The following is a description of a gene set: species: Mus musculus Genes positively differentially expressed in cell type: NK cell upon treatment with cytokine: IFN-β in mouse lymph nodes in vivo. Cytokines mediate cell-cell communication in the immune system and represent important therapeutic targets. A myriad of studies have highlighted their central role in immune function, yet we lack a global view of the cellular responses of each immune cell type to each cytokine. To address this gap, the authors created the Immune Dictionary, a compendium of single-cell transcriptomic profiles of more than 17 immune cell types in response to each of 86 cytokines (>1,400 cytokine-cell type combinations) in mouse lymph nodes in vivo. A cytokine-centric view of the dictionary revealed that most cytokines induce highly cell-type-specific responses. For example, the inflammatory cytokine interleukin-1β induces distinct gene programmes in almost every cell type. A cell-type-centric view of the dictionary identified more than 66 cytokine-driven cellular polarization states across immune cell types, including previously uncharacterized states such as an interleukin-18-induced polyfunctional natural killer cell state. Mouse Gene Set: CUI_NK_CELL_IFNB_RESPONSE_UP from publication Cui A, Huang T, Li S, Ma A, Pérez JL, Sander C, Keskin DB, Wu CJ, Fraenkel E, Hacohen N (PMID 38057668), and this is the list of marker genes: Psmb2, Etnk1, Sp100, Mrto4, Parp14, Crem, Tmem243, Tmsb10, Mrpl30, Tor3a, Hspe1, Ptpn1, Magohb, Helz2, Igtp, Lilrb4b, Cyrib, Parp9, Rsad2, Ifih1, Cytip, Cd86, Gcnt1, Hspa8, Clec2d, Zup1, Socs1, Vps37b, Plac8, Tmbim6, Larp7, Trafd1, Ifrd2, Nedd9, Ptges3, Cish, Cd164, Abracl, Snrpd1, Cct5, Ufd1, Gbp4, Sar1a, Tcp1, Phf11c, Daxx, Nhp2, Ddx60, Evi2a, Zfp593, Trim12c, Apobec1, Pnpla2, Gng2, Tubb4b, Atp6v1g1 (ATPase, H+ transporting, lysosomal V1 subunit G1), Nop56, Adar, Nfkbiz, Ahsa1, Agpat3, Tes, Dtx3l, Ifi204, Map2k1, Ran, Ms4a4c, Tcstv4, Gng12 (guanine nucleotide binding protein (G protein), gamma 12), Gns, Selenok, Parp12, Slfn5, Pdia3, Dnajb11, Sfxn2, Atp5pb, Bag1, Cd69, Nars1, Rtp4, Ifi203, Gbp8, Creld2, Xcl1, Tmem248, Gnpnat1, Pomp, Laptm4a, Aurkaip1, Irf8, Casp1, Pole3, Slamf7, Bst2 (NCBI Gene Id 97478), Stat1, Cct7, St6galnac4, Mat2a, Isg15, Dnaja1, Sh2d1b1, Rnf213, Slfn1, Ebna1bp2, Timm8a1, Nt5c3, Hspd1, Exosc3, Ddx39a, Dkc1, Napsa, Svbp, Arf6, Ms4a6b (membrane-spanning 4-domains, subfamily A, member 6B), Sell, Arpc5, Psmb8, P2ry14, Strap, Ppa1, Psma5, Cntrl, Cysltr2, Smndc1, Ssr1, Gbp2, Bltp3b (NCBI Gene Id 97652), Ccnd2, Fyn, Lgals9, B4galt5, Rel, Aldoa, Nfkbib, Dgkh, Jaml, Ywhae, Myc, Nlrc5, Tbx21, Ifi213, Sp110, Ezr, Calr, Capza2, Usp18, H2-D1, Fhl2, Eif2ak2, Epsti1, Fnbp4, Cd47, Plaat3, Pgd, Zbp1, Ndufb4, Cpne3, Tap2, Ctss, Gbp7, Nab1, Gbp5, Rbm3 (NCBI Gene Id 72067), Txn1, Srsf6, Gnl3, Nop58, H13, Ncl, Ccrl2, Rigi, Mapkapk2, Max, Gadd45g, Tmem184b, Sub1, Cxcl10, Smchd1, Stom, Ptma, Sdc3, Ahr, Ifi214, Eif1, Ly6a, Tspan13, Mx1, Psma2, Lamp2, Nkg7, Ddx21, Klrk1, Nip7, Nampt, Derl2, Riok1, Gzmb, Pa2g4, Dph3, Irf1, Phf11b, Fam111a, Irgm1, Lsm4, Znfx1, Cd53, Apobec3, Myd88, Iigp1, Prps1, Nmi, Actg1, Dennd4a, Gbp9, Oasl1, Plscr1, 9930111J21Rik2, Furin, Bzw1, Rabepk, Psmc4, Tspo, Tnfsf8, Tmed10, Tdrd7, Prkcq, Magoh, Lilrb4a, Dhx58, Parp10, Tapbp, Cmpk2, Rab5c, Ccl3, Snx3, Actr3, Arf1, Cct3, Ostc, Hsp90aa1, Pfdn2, Bbx, Trim34a, Samsn1, Sipa1l1, Gem, Pttg1, Usp25, Gpr65, Tap1, Phf6, Nsd3, Eif5a, Samd9l, Xbp1, Rab8b, Serpina3f, Frmd4b, Casp4, Eif4e, Stk39 (serine/threonine kinase 39), H2-Q7, Ndufs4, Ifi211, Baz1a, Dgat1, Rfk, Eef1e1, Sec61g, Gpr171, Mitd1, Mov10, Spcs2, Emc7, Trim25, Ifitm3, Ccl4, Psmb10, Slfn8, Ubald2, Il12rb1 (interleukin 12 receptor, beta 1), Psma3, Ddx24, Ube2i, Sem1, Cacybp, Stat2, Cox17, Anapc15, Serpinb9 (NCBI Gene Id 20723), Ccr5 (NCBI Gene Id 235693), Slc44a2, Wdr43 (NCBI Gene Id 72515), Impdh2, Slfn2, Vps54, Crlf2, H2-T23, Top1, Tent4a, F2r, Dda1, Orai1 (ORAI calcium release-activated calcium modulator 1), Gzma, Mxd1, Uchl3, Picalm, Larp1, Trim30d, Rars1, Mindy3, Trim30a, Ogfr, Mctp2, Hectd1 (NCBI Gene Id 320157), Serpina3g, Pam16, G3bp1, Chmp4b, Marchf5, Klri2, Herc6, Psmb9, Ifi35, Oas3, Ppp1r11, Cycs, Asb13, Ifng (NCBI Gene Id 15978), Phf5a, Ifit1bl1, Cct2, Isg20, Sytl3 (NCBI Gene Id 83672), Prpf38a, Ifi44, Ascc3, Xaf1, Ndufab1, Sumo1, Oas1a, Selenos, Gch1, Stx11, Ehd4, Ccdc25, Eif2s2, Manf, Hsh2d, Gsdmd, Psme1, Tnfrsf1b, Treml2, Hsp90ab1, Clpb, Ms4a4b, Prf1, Pwp1, Il2rb, Ifit3, Ifi206, Shisa5, B2m, Prelid3b, Psme2, Arf4, Il10ra, H2-K1, Oasl2, Lgals3bp, Pcbp1, Car5b, Trim30c, Desi2, Bcl3, Clic4, H2-T22, Ifi209, Nfkb2, Metrnl, Phf11a, U2af1, Egr1, Il2ra, Ifi47, Ivns1abp (NCBI Gene Id 98245), Pml, Ly6e, Morc3, Tor1aip1, Mrpl32, Hnrnpdl, Supt6, Ifi208, Tmed5, Srsf3, Coro2a, Ifit1, Psma4, Hsph1, Map3k8, Stat3, Rnf114, Psmd11, Pim1, Eif4a1, Selenow, Myl12a, Tuba1c, Gpr18, Litaf, Fyb1, Xdh, Chchd1, Mndal, Ube2q1, Ncr1, Eloc, Hnrnpab, Snx2, Stip1, Rrp1b, Slc25a5, Ube2l3, Nolc1, Ranbp1, Hnrnpd, Ifit2, Adora2a, Cyb5b, Odc1, Chordc1, Tmem33, Srsf7, Fasl, Hspa5, Samhd1, Farsa, Naa20, Mbnl2, Casp8, Rilpl2, Socs3, Cnp, Pdia6, Atp2a2, Tor1aip2, Gmppb, Srpra, Ifi27l2a, Ppid, Ifit3b, Slc35b1, Cers6, Slfn9, Srsf2, Med28, Ube2a, Tpm4, Irf7, Plek, Runx3, Slco3a1, Mrpl52